The following is a description of a gene set: part of: Cell surface interactions at the vascular wall Reactome Pathway: Basigin interactions Basigin is a widely expressed transmembrane glycoprotein that belongs to the Ig superfamily and is highly enriched on the surface of epithelial cells. Basigin is involved in intercellular interactions involved in various immunologic phenomena, differentiation, and development, but a major function of basigin is stimulation of synthesis of several matrix metalloproteinases. Basigin also induces angiogenesis via stimulation of VEGF production.<br>Basigin has an extracellular region with two Ig-like domains of which the N-term Ig-like domain is involved in interactions. It undergoes interactions between basigin molecules on opposing cells or on neighbouring cells. It also interacts with a variety of other proteins like caveolin-1, cyclophilins, integrins and annexin II that play important roles in cell proliferation, energy metabolism, migration, adhesion and motion, especially in cancer metastasis. studied in species Homo sapiens, and this is the list of marker genes: ATP1B3, PPIA, ATP1B2, SLC16A1, ATP1B1, SLC7A10, ITGA3, BSG, SPN, MAG, ITGB1, SLC16A8, SLC3A2, SLC7A7, SLC7A8, SLC16A3 (solute carrier family 16 member 3), PPIL2, L1CAM, MMP1, SLC7A11, SLC7A6, SLC7A9, ITGA6, SLC7A5, CAV1